Given this list of marker genes ABCF1, DSC1, F5 (coagulation factor V), ZNF132, MSL3, BEND5, LDHB, PLCL2, MTM1, MAPKAPK5, AP1G2, ITPA, PIM2, LDLRAP1, TGFBR2, PLSCR3, FMNL2, HS3ST3B1, ECE1, MATCAP2, C1QTNF6, PRL, BZW2, WNT7A, SLC38A2, HSF5, C15orf32, CDC25B, RCAN1, ABCA7, CUL9, PFAS, TRABD2A, FCMR, LRPPRC, KCNQ1, TPP2, TCEA3, RPL23A, SFXN1, SPP1, KRT73, L1TD1, METAP1D, YBX1, NLN, CSGALNACT1, BEX3, DCK, UBTF, GPA33, ATP6V0E2, MAL, CYP3A43, CNST, DENND11, SNORD115-24, PRKAR1B, NFKBIZ, PAICS, RECQL5, KRT72, CLDN8, HOOK2, LRRN1, AGBL3, TRPC2, NET1 (neuroepithelial cell transforming 1), BLMH, PPA1, DPEP2, XPO6, SMAP2, ATXN2L, PTPN6, ANKRD16, SLC6A15, PPARGC1B, RABL3, CEP68, KLF3-AS1, PNPO, TTTY10, TKT, HAVCR2, MMS19, BLNK, UBQLN1, LMLN, MT1L, ZNF563, AIP, MDN1, KIAA0319, LMBR1L, GAL3ST4, NFKB2, OR52J3, TIMD4, SFXN5, SELP, ADGRE1, DIPK1A, TLR5, SHMT2, IL4R, OLFM2, SNORD115-33, TRAP1, SAYSD1, AP1M1, KLHL3, CD79A, HAVCR1, ORMDL3, EIF1AY, DPH5, MRPS26, MRPS24, FANCD2, FLCN, SDK2, ANP32B, MACROH2A1, MAN1C1, TSGA10 (testis specific 10), PRPF19, PPFIBP2, SULT1B1, HSPD1, FCER1G, LRRC8C, OR1F2P, RANBP3, PITPNM2, SESN3, TXLNGY, TCP11L2, MAP4K2, ZC3H12D, BRD3, CCNE1, PELI1, ESYT2, PCYOX1L, FHIT, ENSG00000124835, GOLGA7B, AKR1E2, SPTBN1, CARMIL1, NUDCD3, CNTNAP4, FOXP1, DSPP, LGALS17A (NCBI Gene Id 400696), IGSF9B, RNF138, ZBTB18, MCCC2, RIPOR2, COX4I1, TNFRSF10D, CRTC3, NOSIP, RASA3, UBE3D, PTPRK, NAT10, MPI, FNTB, PHF19, RERG, FGD3, C1QBP, RIC3, TESPA1, EFCAB13, CDK4, ANKRD26, ADGRE4P, KCNJ13, NELL2, MEF2C, CDCA7L (cell division cycle associated 7 like), BMERB1, RBM26, STK26, GPX6, NOG, ACBD4, CHMP7, GRAP (GRB2 related adaptor protein), ADD2, TCEA2, MYB, FAM117B, here is a description of the gene set: Human Gene Set: GSE5542_UNTREATED_VS_IFNG_TREATED_EPITHELIAL_CELLS_6H_UP Genes up-regulated in epithelial cells (6h): untreated versus IFNG. from publication Sanda C, Weitzel P, Tsukahara T, Schaley J, Edenberg HJ, Stephens MA, McClintick JN, Blatt LM, Li L, Brodsky L, Taylor MW (PMID 16800785) Type I and type II interferons (IFNs) bind to different cell surface receptors but activate overlapping signal transduction pathways. We examined the effects of a type I IFN (IFN-acon1) and a type II iFN (IFN-g1b) on gene experession in A549 cells and demonstrate that there is a common set of genes modulated by both IFNs as well as a set of gene specifically regulated by each, reflecting the activation of different signaling pathways. In particualr, IFN-g induced many more genes of the signaling pathways, apoptosis, and cytokine interactions than did IFN-a. Even with genes induced by both IFNs there were distinctive quantitativive differences in expression. IFN-g1b plays a major role in the induction and regulation of the complement pathway. Previous work has shown a synergistic antivral and antiproliferative effect of type I and type II IFNs in cell culture and in the treament of tumors in mice. We demonstrate that a majority of genes showed and additive effect of IFN-acon1 and IFN-g1b, but a subset of gene is synergistically induced; these incluce ISG10, MX2, OAS2, and other genes known to be involved in the antiviral response, TRAIL (TNFSF10) and caspases involved in apoptosis and chemokine genes RANTES, CXCL10, and CXCL11. Greater than additive transcription of some of these genes in the presence of both IFNs was confirmed by real-time kinetic RT-PCR. Elevated induction of many of these genes may be sufficient to explain the synergistic antiviral and antitumor effects of this combination of IFNS in vivo. studied in species Homo sapiens